Given this list of marker genes MALT1, CARD9, CARD10, BCL10, CARD11, here is a description of the gene set: Human Gene Set: GOCC_CBM_COMPLEX species: Homo sapiens A protein complex comprising Bcl10, MALT1 and a CARD domain-containing protein (CARD9, CARD10 or CARD11); plays a role in signal transduction during NF-kappaB activation.